The following is a description of a gene set: studied in species Mus musculus Mouse Gene Set: GOBP_ARTICULAR_CARTILAGE_DEVELOPMENT The process whose specific outcome is the progression of articular cartilage over time, from its formation to the mature structure., and this is the list of marker genes: Ift80, Ogn, Dspp, Bgn, Epyc, Pbxip1, Optc, Enpp1